The following is a description of a gene set: Mouse Gene Set: GOBP_G1_TO_G0_TRANSITION_INVOLVED_IN_CELL_DIFFERENTIATION A cell cycle arrest process that results in arrest during G1 phase, whereupon the cell enters G0 phase, in the context of cell differentiation. studied in species Mus musculus, and this is the list of marker genes: Zfp503, Cdk5r1, Gata6, Capn3, Rnf112